The following is a description of a gene set: Human Gene Set: MIR320E species: Homo sapiens Genes predicted to be targets of miRBase v22 microRNA hsa-miR-320e in miRDB v6.0 with MirTarget v4 prediction scores > 80 (high confidence targets). from publication Chen Y, Wang X (PMID 31504780), and this is the list of marker genes: POGZ, PNRC1 (proline rich nuclear receptor coactivator 1), COPA, ULK1, WDR26, CDC25A, ARHGAP19, EPHA7, ZCCHC3, DAZL, SORBS2 (NCBI Gene Id 8470), STUM, VEGFD, RHOG, CDKL5, TMEM47, USP48, SLC6A17, FBXO45, DAB2, CYP26A1, PARP8, NR2C2, TSHZ3, LAPTM4A, JMY, SOX11, SLC10A3, DCT, LMF1, MAB21L1, CNOT7, OCIAD1, BEX1, GTF2A1, TMOD3, SLC22A23, RFX3, MINDY2, RBPJ, ZNF500, PPP1R9B, STT3B, HIPK2, TCEA1, CNTLN, SKA3, CEP41, RBM15, AQP1, TDG, USP9X, KCNA6, BLOC1S5, EIF4EBP2, CFAP54, RAB33B, ZNF3, CLASP1, SETD5, ZNRD2, HDGFL3, MICAL3, TEAD1, ABR (ABR activator of RhoGEF and GTPase), PLEKHA4, ORMDL1, CHRNA2, ERP44, ZRANB2, ZNG1E